Given this list of marker genes H1-2, KPNA1, DFFB, H1-5, KPNB1, H1-0, HMGB1, CASP3, HMGB2, H1-4 (H1.4 linker histone, cluster member), DFFA, H1-1, H1-3, here is a description of the gene set: Reactome Pathway: Apoptosis induced DNA fragmentation part of: Apoptotic execution phase DNA fragmentation in response to apoptotic signals is achieved, in part, through the activity of apoptotic nucleases, termed DNA fragmentation factor (DFF) or caspase-activated DNase (CAD). In non-apoptotic cells, DFF is a nuclear heterodimer consisting of a 45 kD chaperone and inhibitor subunit (DFF45)/inhibitor of CAD (ICAD-L)] and a 40 kD nuclease subunit (DFF40/CAD)( Liu et al. 1997, 1998; Enari et al. 1998). During apoptosis, activated caspase-3 or -7 cleave DFF45/ICAD releasing active DFF40/CAD nuclease. The activity of DFF is tightly controlled at multiple stages. During translation, DFF45/ICAD, Hsp70, and Hsp40 proteins play a role in insuring the appropriate folding of DFF40 during translation. The nuclease activity of DFF40 is enhanced by the chromosomal proteins histone H1, Topoisomerase II and HMGB1/2. In addition, the inhibitors (DFF45/35; ICAD-S/L) are produced in stoichiometric excess. species: Homo sapiens